The following is a description of a gene set: studied in species Homo sapiens Enables the transmembrane transfer of a calcium ion by a channel that opens when glutamate has been bound by the channel complex or one of its constituent parts. Human Gene Set: GOMF_GLUTAMATE_GATED_CALCIUM_ION_CHANNEL_ACTIVITY, and this is the list of marker genes: GRIK1, GRIK2, GRIA1, GRIK3, GRIN2A, GRIN2D, GRIN2B, GRIN1, GRIA3